The following is a description of a gene set: Mouse Gene Set: REACTOME_MAPK6_MAPK4_SIGNALING studied in species Mus musculus MAPK6/MAPK4 signaling, and this is the list of marker genes: Psmd2, Ccnd3, Cdc42, Uba52rt, Psmd12 (NCBI Gene Id 66997), Psmc2, Psmd3, Psmb5 (proteasome (prosome, macropain) subunit, beta type 5), Uba52, Psmd8, Cdc42ep3, Mapk6, Psmc3, Cdc14a, Rac1, Prkacb, Psmd14, Etv4, Psmb3, Psma7, Cdc42ep5, Psmc4, Pak2, Hspb1, Psma6, Psmd13, Psma2, Psmb1, Psmd1, Rps27a, Foxo3, Psmd11, Psmc1, Prkaca (NCBI Gene Id 18747), Psma4, Adrm1, Cdc14b, Psmb7, Psmc5, Psmd7, Dnajb1, Pak1, Psmb6, Ubc, Psmd6, Foxo1, Septin7, Psma1, Psmb2, Xpo1 (exportin 1), Psmc6, Kalrn, Psmb4, Psma3, Psma5 (proteasome subunit alpha 5), Pak3, Mapk4, Cdk1, Mapkapk5, Cdc42ep2, Ubb